The following is a description of a gene set: Binding to a microRNA, a 21-23 nucleotide RNA that is processed from a stem-loop RNA precursor (pre-miRNA) that is encoded within plant and animal genomes. species: Mus musculus Mouse Gene Set: GOMF_MIRNA_BINDING, and this is the list of marker genes: 2810429I04Rik, Fgfr3, Matr3, Pou5f1, Sox2, Zc3h7b, Zfp346, Trim71, Zc3h12a, Ago2, Spout1, Elavl1, Hnrnpa1, Zc3h10, Zc3h7a, Tut7, Lin28a, Kcnq1ot1, Mir484, Rbm4, Ago3, Ybx1 (Y box protein 1), Pnpt1, Gm15290, Socs3, Dnd1, Fmr1, Ago1, Dicer1, Pum2, ENSMUSG00000126352, Sox4, Mir361, Ddx21, Rc3h1, Hnrnpa2b1 (heterogeneous nuclear ribonucleoprotein A2/B1), Ago4, Rbm10, Qki, Tut4, Pum1, Tarbp2